Given this list of marker genes Slc4a3 (solute carrier family 4 (anion exchanger), member 3), Ryk, Auts2, Rex1bd, Dhx37, Sec14l1, Phf21b, Dnajc30, Gtpbp6, Ccdc80, Ppcs, Hip1r, Sez6l2, Ripk1, Usp10, Sf3b5, 4930413F20Rik, Foxj3, Kif21b, Lcmt2, Nagpa, Sh3yl1, Zfp692, Snph, Fth1, Anxa3, Exosc8, Lamtor4, Vcf1, Krt8, Tmem175, Abhd17a, Gm15663, Trpc1, Pianp, Scand1, Ehmt2, Cdk12, Rapgef4, Col1a1, Ctc1, Zfand3, Rnf138, Trp53rkb, H2-K1, Wdr75, Ptprs, Slc25a42, Agpat5, Ptprn, Pdk1, Isy1, B4galt5, Slc25a27, Sez6, Poc1a, Sf3a2, Cttnbp2, Elac1, Fem1b, Tmem240, Adcy5, Rnf208, Brme1, Cttnbp2nl, Megf8, Map1s, Zfp428, Mrpl24, Rbm12, Map2k2, Icmt, Ankrd13d, 3110009E18Rik, Agbl4, Fbxo2, Cyb5d2, Fam110d, Exosc1, Taf5, Snrpc (NCBI Gene Id 20630), Cep135, Fam20a (FAM20A, golgi associated secretory pathway pseudokinase, NCBI Gene Id 208659), Hdac7, Fem1c (fem 1 homolog c), B130024G19Rik, Frs2 (fibroblast growth factor receptor substrate 2), Slc9a6 (solute carrier family 9 (sodium/hydrogen exchanger), member 6), H2-D1, Ttc14, H2-Eb1, Selenow, Qdpr, Mrm3, Tmsb10, Rpl35, Nutf2, Slc35d1, Taco1, Gm15760 (NCBI Gene Id 100042948), Tmsb4x, Dxo, Ttc9b, Vegfa, Vps11, Brd10, 1110065P20Rik, Pik3r4, Luc7l2, Map3k3, Lamc1, Sirpa, Aacs, Schip1, Slc36a1, Sgce, Exosc6 (exosome component 6), Ap5z1, Klhl33, Rps27l, Nr2c2ap, Gucy2g, Pon2, Pomc, Nova1, Trim67 (NCBI Gene Id 330863), Lypd8, Dpf1, Wipi1, Akr1e1, Zfp82, Rpl13a, Itgb1bp1, Mien1, Ttyh1, Scp2, Arih1, Pacs1, Samd4b, Iqsec2, Fam98c, Them4, Pde8b (phosphodiesterase 8B), Grb10, Stk38, Tbc1d7, Ap2b1, Ins2, Ado, Tsc1, Pgp, Dcn, Mrps21, Mfsd13a, B4galt7, Fcmr, Pcp4, Kansl1l, Prkar2a, Vwa5b2, Srcin1, Atp6v0c, Vegfb, Adgrb1, Qsox1, 4930590J08Rik, Arhgef40, Arpc3, Sidt1, Sft2d1, Rbm7, Fryl, Pck2, Arhgap17, Tssc4, Zyx, Nfat5, Gtpbp2, Mpc1, Arpc1b, Mrpl33 (mitochondrial ribosomal protein L33), Ypel4, Particl, Rab11fip2, Jag2, Vps13d, Lrrfip1, Mycbp2, Fbln1, Prkd3, Fbxl15, Gid8, Sorbs3, Mir124a-1hg, Nicol1, Mettl1, Fam161a, Pabpn1, Terf1, Flna, 2310022B05Rik, Heatr5b, Celf5, Polr2i, Sap130, Ube2m, Ammecr1l, Enoph1, Nabp2, Pet100, Acvr2b, Gpr27, Rps3 (ribosomal protein S3), Bola2, Ttc13, Gstm1, Plod1, Kank3, Chka, Csnk1g2, Diras1, Klhl23, Prrc1, B2m, Fabp5, Arpc2, Eri2, Bgn, Chd5, Zfp362, Stard10, Evl, Map3k10, Trrap, Stxbp4, Fam3d, Basp1, Pus10, Il15ra (interleukin 15 receptor, alpha chain), Ube2z, Adcy9, Trf, Cyp4f16, Ccdc85b, Thoc6, Clic4, Mllt1, Lzts3, Mrpl20, Mast3, Lhfpl5, Gm15446, Casc3, Mtnap1, Tspan14, Cbl, 5031439G07Rik, Ccar2, R3hcc1, Cd9, Lyz2, Pstk, Focad, Tfdp2, Zcchc14, Adgrb3, Ccdc9, Kiz, 5031425E22Rik, Eif2b4, Sdc4, Cat, Nfkbil1, Zc3h6, Epb41l4b, Mbp, Gm16894, Rdh13 (NCBI Gene Id 71482), Src, Gm14295, Gtf3c5 (general transcription factor IIIC, polypeptide 5), Zfp708, Zfp827, Sap30l, Arl5b, Ufsp1, Arap2, Zfp786, Mapk8ip1, Tsr1, Polr3e, Safb2, Cep95, Rpl17, Rrbp1, Acp6, Rpl26 (NCBI Gene Id 19941), Neurod2, Ppp1r9b, Bcl2, Fxr2, Snhg7, Galnt9, Rpl13, Itpr1, AW495222, Kctd1, Cystm1, Kctd17, Ulk2, Ppp1r35, Gar1, Rsu1, Bend5, Kctd20, Iqcc, Ppp1r11, Stx16, Stk11ip, Apoe, Pnisr, Mrpl48, Gm6981, Caprin2, Dnajc1, Kpna4, Srebf2, Ptpmt1, Plpp3, R3hdm4, Prr13, Nktr, Endog, Bahcc1, Rps20, Tmem42, Rell2, Mtmr10, 4930512B01Rik, Cdk5r1, Slc10a3, Rtl8a, Ptrhd1, Cul9, Trappc6a (trafficking protein particle complex 6A), Mterf2, Mink1, Apoo, Prickle1, Alas2, Pdzd4, Adap1, Iffo2, Ifnar1, Pycr3, Haghl, Wdr59, Pick1, Gnb2, Mast1, Cdkn2aip, Trim47 (NCBI Gene Id 70124), Tunar (Tcl1 upstream neural differentiation associated RNA), Nhlrc3, Sdcbp2, Gm5113, C1qtnf1, Swi5, Fbl, Klc2, Ddit4 (NCBI Gene Id 74747), Trim68, Adgrl1, Tgfb1i1, Snrpd2, BC005624, Cpt1c, Arf5, Chchd10, Ginm1, Commd9, Akap13, Lrrc14, Numbl, Serpinb6a, Txnrd1, Gpr162, Camk2n1, Dpyd, Cebpd, Serp2, Adcy1, Pstpip2, Trio, Inf2, Bsn, S1pr1, Dmrtc1a, Dock7, Mrpl13, Zdhhc4, Gm13889, Tab1, Cst3, Jam3, Ccdc13, Chi3l1, Timp4, Slc1a6, Fxyd1, Lrp1, Ltbp1, Nuak1, Rpl29, Asphd1, Pigh, Zfyve9, Pvalb, Fam228b, Rwdd4a, Tchh, Vps37d, Ftl1, Gm38353, Prrg2, Tedc2, Tgfbr2, Mdga2, Mrps16, Plekhj1, Ptges3l, Them6, Atp6v0d1, Tigd5, Atp5mc2, Ppa2, Gpx8, Mon2, Hcn2, Ino80e, Pafah2, Cdhr3, Nol3, Dmd, Ly6h, Pcdhgc4, Mcm3ap, Zfp874b, Mylk, Prr5l, Manbal, Pcsk1, H2bc4, Ell, Sema6b, Uchl3, Pdcd5, Cacna1g, Celf3, Adamts1, Fbxw8, Zfpl1, Arhgap27, Cog1, Ptgds, Ncmap, Nrxn2, Fam171a2, Cacna1a, Magi2, Sptbn4, Rgl2, Rps3a1, Anks1, Mgp, Msra, Pnpla6, Ring1, Unkl, Inpp5e, Hpgds, Plekho1, Armc9, Nsun5, Cdc42se1, Ndrg2, Gm10584, Kctd16, Lrrc42, Tomm6, Col3a1, Senp6, Amer3, Tmem208 (transmembrane protein 208), Mrpl21, Pitpnm2, Drap1, Borcs6, Sod3, Grik5, U2af1, Pcsk1n, Prkcg, Zfp821, Eif6, Med19, Tyro3, Vim, Zfp111, Gpx1, Cyth1, Ftsj1, Adam11, Polr2j, Fig4, Rnf182, Shank3, Zfp622 (zinc finger protein 622), Tmem101, Prrt1, Gga1, Pdss2, Dgcr6 (DiGeorge syndrome critical region gene 6), Srrm3, Nr2c1, Actr6, Clk2, Slc25a35, Ift43, Get3 (NCBI Gene Id 69844), Aldh5a1, Oxct1as, Lrrc4, Wwox, Tex261, Sptbn2, Msl3, Malsu1, Mpv17l2, Zfp599, Dync2i1, Hmgcs2, Med13l, Camk2a, B4galnt4, Zfp36, Cdc42ep1, Hsd17b11, Mrps12, Mrpl22, Ccny, Smarcd3, Chst1, Fmn2, Taf7, Tmem39b, Adgra2, Atp11b (NCBI Gene Id 76295), Insyn1, Tmem41a, Vps26c, C2cd3, Ap2a1, Pfn1, Arl3, Exoc6b, Radil, Pcyt2, Rps7, Ndufb7, Coro1b, Spr, Chd8 (chromodomain helicase DNA binding protein 8), St6gal2, Hadh, Swsap1, Nxph3, Ppp1r1a, Slc1a3, Fkbp10, Tmem88, Mt1, Lypla2, Myo1c, Agap3, Usp20, Gpx3, Ift80, Cd74, Tnip1, Spint2, Akap8, Smim29, Prkce, Clvs2, Palm, Nmnat1, Prmt3 (protein arginine N-methyltransferase 3), Atp1a2, Csrp1, Sult2b1, Smpdl3b, Rmdn1, Tnk2, Rnf157, Crtc3, Tsr3, Acadvl, Acbd6, Nup160, Trak1, Ralgds, Pla2g4e, 9130401M01Rik, Jund, Gria1 (NCBI Gene Id 72995), Mapk3, Grin2b, Mblac1, Tmc7, Rars2 (arginyl-tRNA synthetase 2, mitochondrial), Pfdn2, Snf8, Smarcd1, Tars3, Nr2f1, Nacc2, Bri3, Gstt1, Smim20, Rnd2, Btg2, Tuba1c, A230057D06Rik, Sharpin, Selenop, Phospho2, Syt7, Mfn1, Zpbp, Anxa2, Begain, Ark2c, Baiap2, Gpatch1, Wwtr1, Mypop, Pltp, Lrrc32, Iqgap1, Rasgef1a, Bcl9l, Otud7a, Fgf5, Ralbp1, Zfp575, Capg, Dtx3, Gpr137c, Elp2, G2e3, Hyal3, Fgf11, Nrgn, Car11, Gper1, Srrm1, Pmepa1, Gadd45gip1, Smad7, Caln1, Ptpa, Krt15, Clec16a, Ano4, Ntm, Stau1, Adh1, Klf4, Clip2, Zfp804a, Rpf1, Iapp, Tgoln1, Nup153, Chd4, Prc1, Plp1 (proteolipid protein (myelin) 1), Tbcd, Pde4a, Synpo2, Aldoc, Grcc10, Mrpl16, Adamtsl5, Nfasc, Rpl32, Cyp20a1, Dido1, Zfp335 (NCBI Gene Id 69801), Gad1, Cacng2, Ube2o, Pias4, Zfp771, Ddah2, Ctsc, Mtln, 1700109H08Rik, Tcp11l1, H2-Aa, Zfp324, Zfp956, Rpl30, Atp8a1, Pcgf2, Tmem100, Mecr (NCBI Gene Id 26922), Arl6ip4, Ptpn5, Madd, Slc25a18 (NCBI Gene Id 71803), Pxmp4, Mxd4 (Max dimerization protein 4), Rps24, Abcc5, Xrn2, Plvap, Spata31f3, Glrx5, Ubxn1, Exoc6, Kdm6a, Stmn4, Cracr2b, Nat8f4 (NCBI Gene Id 75541), Tmem259, Pelp1, Eif3j2, Cant1, E530011L22Rik (NCBI Gene Id 320301), Dynll2, Ulk1, Ncan, Brap, Zbed6, Mettl8, Fdx2, Rnf149, Rasl11a, Usp31, Maz, 5430416N02Rik, Chmp4b, Lsm4, 1500012K07Rik, Lmo4, Zgpat, Rundc3a, Pappa (NCBI Gene Id 71487), Shq1, Ddx10, Clcn6, Gramd4, Tppp3, Spg7, Per1, Srf, Obsl1, Ifitm10, Vgf, Col1a2, Tfpt, Chd3, Rpsa, Fkbp3, Adamts17 (ADAM metallopeptidase with thrombospondin type 1 motif 17), Mamdc2, Ndufa12, Dcdc2a, Slc25a25, Ccdc73, Cnih2 (cornichon family AMPA receptor auxiliary protein 2), Nectin1, 1700113A16Rik, Asb6, Ndufb4, Pycr1, S100b, Epg5, Khsrp, Fh1, Sema4g, Bax, Nkd1, Plscr1, Ndufaf2, Skic2, Mospd2, Pfdn1, Hs3st4, Keap1, Card19, Sparc, Pdlim3, Irak4, Phf2, Ptgis, Zranb1, Txndc11, Grin1, AU040320, Lrrc4b, H2ac13, Mtss2, N4bp2, Dctn6, Mapk11, Sfxn3 (sideroflexin 3), Dgkz, Vgll4, L3mbtl2, Arel1, St14, Cldn5, Sema5b, Tomm6os, Kdm6b, Nt5c, Cep164, Mfap1b, Scnm1, Phldb2, A930015D03Rik, Mettl14, Tle5, Sphk2, Mbip, Rbm22, Trank1, F8a, Gpr137, Slc1a2, Hdac5 (histone deacetylase 5), Med10, Rtf1, Serpinf1, Panx2, Dbp, Ctdsp1, Ssbp4, Erdr1, S100a16, Gigyf1, Zfp787, Pcbd2, Atg4d, Mrps24, Fem1al, Gfpt1, Zfp85os, Pla2g4b, Mfap4, Ercc6, Ppp1r12c, Matk, Atox1, Il6ra, Ppic, Ablim2, Stk40, Mag, Mir9-3hg, Cirbp, Acaa2, Spns2, Gpr150, Rasl10b, Tmem160 (NCBI Gene Id 69094), Ajm1 (apical junction component 1), Tektip1, Mideas, Gstm6, Ankrd54, Glt8d1, H2az2, Icam1, Ctnnd2, Gpt, Glrx3, Hook2, Kyat1, Rbfox3, Gatm, Ccr7, Acvrl1, Tmem67, Efcab15, Ctbs, Rps15, Ppp1r1b, Comtd1, Cfh, Cnot10, Ing4, Dusp23, Rpl18, Kcnj6, Gsn, Lpcat2, Tbc1d1, Zfhx2, Dennd1b, Jpt1 (NCBI Gene Id 15374), Slc30a4, Lgals8, 2410021H03Rik, Zbtb22, Yeats2, Taok2, Gm15612, 1700025G04Rik, Sco2, Hpca, Uqcc6, Phgdh, Fcgrt, Zbtb49, Pou3f1, Rfng, Ptms, Lurap1l, Nln, Serinc2, Pex6, Cd177, C1qtnf4, Thy1, B9d2, Lum, Trub2, Arrb2 (arrestin, beta 2), Zfp647, Niban2, Gpatch8, Commd4, Dapk3, here is a description of the gene set: Mouse Gene Set: TABULA_MURIS_SENIS_BRAIN_NON_MYELOID_NEURON_AGEING from publication Tabula Muris Consortium (PMID 32669714) studied in species Mus musculus